The following is a description of a gene set: Human Gene Set: MIR218_2_3P studied in species Homo sapiens from publication Chen Y, Wang X (PMID 31504780) Genes predicted to be targets of miRBase v22 microRNA hsa-miR-218-2-3p in miRDB v6.0 with MirTarget v4 prediction scores > 80 (high confidence targets)., and this is the list of marker genes: SCAI, SYPL1, COL6A5, DEFB110, HSF2 (NCBI Gene Id 3298), GID8, GOLIM4, BMP6, ZC3H11A, SKIDA1, NUFIP2, C12orf76, EIF4H, DNAL1, CAVIN4, RTKN2, COL6A1, CACNA2D1, DUSP13A, DSG3, UGCG, ZNF354C, OLA1, SLC25A40, CCND2, MTERF2, FAM168A, POM121C, PPIL1, PHACTR1, ALAD (aminolevulinate dehydratase), PTPN2, ADAMDEC1, HDAC1, WDR26, PI15, OSGIN2 (oxidative stress induced growth inhibitor family member 2), MORC3, POM121, KIF13A, ZNF33B, ZNF33A, ZNF154, RBM27, ZNF750, SMLR1, TTC13, ZNF585A